Given this list of marker genes APOE, TREM2, CHMP2B, PRNP, MAPT, ABCA7, TMEM106B, VCP, PSEN1, GRN, PSEN2, here is a description of the gene set: Senile plaques Human Gene Set: HP_SENILE_PLAQUES Senile plaques are extracellular deposits of amyloid in the gray matter of the brain. species: Homo sapiens